Given this list of marker genes Zfp36l2, Fzd7, Gm30731, Tgfb2, Wnt7a, Fut10, Hoxb4, Lbh, Fubp1, Fut9, Vangl2, Notch1, Bmi1, Wnt3a, Ulk4, Cdkn2a (NCBI Gene Id 18560), here is a description of the gene set: The self-renewing division of a somatic stem cell, a stem cell that can give rise to cell types of the body other than those of the germ-line. species: Mus musculus Mouse Gene Set: GOBP_SOMATIC_STEM_CELL_DIVISION